The following is a description of a gene set: Generalized cerebral atrophy/hypoplasia Human Gene Set: HP_GENERALIZED_CEREBRAL_ATROPHY_HYPOPLASIA studied in species Homo sapiens Generalized atrophy or hypoplasia of the cerebrum., and this is the list of marker genes: PRRT2, PLA2G6, TBP, FGF13, STX1B, GABRG2, HCN1, SCN2A, SCN1A, GABRD, SCN1B, SCN9A, ADGRV1